Given this list of marker genes MTMR4, LYN, MCM6, SERPINE2 (serpin family E member 2), IDS, SH2B1, TSC22D3, DAXX, TUBB2A, ZBTB14, PARP1, POLR1C, TAX1BP3, ICAM2, NFYA, SELPLG, REEP5, KPNA2, PTPN12, XRCC5, CDK7, ARHGEF1, MPV17, TMED10, PCGF2, SHOC2, TASOR, H2AC6, TAX1BP1, KLC1, RNF144A, HNRNPA3, CENPB, SPINT2, ULK2, LITAF, TXNRD1, B2M, ITPK1, PDLIM5, PLP2, ANP32E, ZFC3H1 (zinc finger C3H1-type containing), OTUD4, CANX, H2AC18, SRF (NCBI Gene Id 6722), SPCS2, TRA2A (transformer 2 alpha homolog), PSMD14, CD47, GOT2, CBX1, CDKN1C, IGKC, MTDH, RPA2, DNPEP, AGPAT1, ATR, ITM2A, UBE2E3, PSMD6, ANXA4, DCTN6, here is a description of the gene set: A major challenge for kidney transplantation is balancing the need for immunosuppression to prevent rejection, while minimizing drug-induced toxicities. We used DNA microarrays (HG-U95Av2 GeneChips, Affymetrix) to determine gene expression profiles for kidney biopsies and peripheral blood lymphocytes (PBLs) in transplant patients including normal donor kidneys, well-functioning transplants without rejection, kidneys undergoing acute rejection, and transplants with renal dysfunction without rejection. We developed a data analysis schema based on expression signal determination, class comparison and prediction, hierarchical clustering, statistical power analysis and real-time quantitative PCR validation. We identified distinct gene expression signatures for both biopsies and PBLs that correlated significantly with each of the different classes of transplant patients. This is the most complete report to date using commercial arrays to identify unique expression signatures in transplant biopsies distinguishing acute rejection, acute dysfunction without rejection and well-functioning transplants with no rejection history. We demonstrate for the first time the successful application of high density DNA chip analysis of PBL as a diagnostic tool for transplantation. The significance of these results, if validated in a multicenter prospective trial, would be the establishment of a metric based on gene expression signatures for monitoring the immune status and immunosuppression of transplanted patients. from publication Flechner SM, Kurian SM, Head SR, Sharp SM, Whisenant TC, Zhang J, Chismar JD, Horvath S, Mondala T, Gilmartin T, Cook DJ, Kay SA, Walker JR, Salomon DR (PMID 15307835) Genes up-regulated in peripheral blood lymphocytes (PBL) from patients with acute transplant rejection compared to those from patients with well functioning kidneys more than 1-year post transplant. Human Gene Set: FLECHNER_PBL_KIDNEY_TRANSPLANT_REJECTED_VS_OK_UP species: Homo sapiens